Given this list of marker genes GATA1, SYT7, SLC4A8, GATA2, STX1A, UNC13D, HLA-F, STXBP1, IL4R, KLRC2, FCER1G, CD160, RPH3A, CDK5, LAMP1, GAB2, ADORA2B, ITGAM, F2RL1, SPHK2, SNX4, SYT10, FGR, PLA2G3, VAMP7, DOC2B, CD177, RAB3D (NCBI Gene Id 9545), SCAMP5, STX4, SYT1, KCNB1, SYK, NLGN1, VAMP8, RAB15, RPH3AL, ZP3, RAB27A, SYT4, RAB3A, ITGB2, HYAL3, CDK5R2, IL13, DOC2A, AP1G1, PPP3CA, CACNA1B, here is a description of the gene set: Any process that activates or increases the frequency, rate or extent of regulated secretory pathway. species: Homo sapiens Human Gene Set: GOBP_POSITIVE_REGULATION_OF_REGULATED_SECRETORY_PATHWAY